The following is a description of a gene set: Human Gene Set: REACTOME_MALATE_ASPARTATE_SHUTTLE Malate-aspartate shuttle studied in species Homo sapiens, and this is the list of marker genes: SLC25A22, SLC25A18, GOT2, SLC25A12, SLC25A13, SLC25A11, GOT1, MDH2, MDH1